Given this list of marker genes RBPJ, DDIT4, CTSS, ADGRG1, ZNRF1, CHIA, ITGAE, ISG20, ZRANB2, here is a description of the gene set: The restriction of influenza A virus replication to mouse respiratory epithelium means that this host response is anatomically compartmentalized, on the one hand, to sites of T cell stimulation and proliferation in the secondary lymphoid tissue and, on the other hand, to the site of effector T cell function and pathology in the pneumonic lung. Thus, it is hardly surprising that virus-specific CD8(+) T cells recovered by bronchoalveolar lavage (BAL) from the infected respiratory tract seem more activated in terms of both cytolytic activity and cytokine production than those cells isolated from the spleen. The present analysis uses Affymetrix microarray technology to compare profiles of gene expression in these two lineage-related, yet anatomically separate, lymphocyte populations. Ninety differentially expressed genes were identified for influenza-specific CD8(+)D(b)NP(366)(+) T cells obtained directly ex vivo by BAL or spleen disruption, with nine genes being further analyzed by quantitative, real-time PCR at the population level. Integrin alphaE, for example, was shown by Affymetrix and real-time mRNA analyses and then by single-cell PCR and protein staining to be present at a much higher prevalence on the BAL CD8(+)D(b)NP(366)(+) set. The unpredicted finding, however, was that mRNA expression for 75% of the genes was lower in T cells from the BAL than from the spleen. Apparently, the localization of virus-specific CD8(+) T cells to the site of virus-induced pathology is associated with a narrowing, or focusing, of gene expression that favors enhanced effector function in the damaged, high-antigen load environment of the pneumonic lung. Human Gene Set: MARSHALL_VIRAL_INFECTION_RESPONSE_UP Genes up-regulated in the influenza-specific CD8+ T lymphocytes from bronchoalveolar lavage (BAL) compared to those from spleen. from publication Marshall DR, Olivas E, Andreansky S, La Gruta NL, Neale GA, Gutierrez A, Wichlan DG, Wingo S, Cheng C, Doherty PC, Turner SJ (PMID 15831586) species: Mus musculus